The following is a description of a gene set: Mouse Gene Set: chr12B2 species: Mus musculus, and this is the list of marker genes: Mir5627, Pnpla8, Gm7370, Nrcam, Dnajb9, Gm6125, Gm2027